The following is a description of a gene set: studied in species Homo sapiens Human Gene Set: GOMF_MAP_KINASE_KINASE_KINASE_KINASE_ACTIVITY Catalysis of the phosphorylation of serine and threonine residues in a mitogen-activated protein kinase kinase kinase (MAPKKK), resulting in activation of MAPKKK. MAPKKK signaling pathways relay, amplify and integrate signals from the plasma membrane to the nucleus in response to a diverse range of extracellular stimuli., and this is the list of marker genes: MAP4K2, MAP4K3, MAP4K4, MAP4K5, MAP4K1, MAP3K7